The following is a description of a gene set: The process that gives rise to the cerebellar granule layer. This process pertains to the initial formation of a structure from unspecified parts. The granular layer is the innermost layer of the cerebellar cortex. This layer contains densely packed small neurons, mostly granule cells. Some Golgi cells are found at the outer border. Granule neurons send parallel fibers to the upper molecular layer, where they synapse with Purkinje cell dendrites. Mossy fibers from the pontine nuclei in the white matter synapse with granule cell axons, Golgi cell axons and unipolar brush interneuron axons at cerebellar glomeruli in the granule cell layer. Human Gene Set: GOBP_CEREBELLAR_GRANULAR_LAYER_FORMATION species: Homo sapiens, and this is the list of marker genes: NRXN1, KNDC1, WNT7A, OPHN1, CBLN1, PROX1, GRID2